The following is a description of a gene set: Hypoxia-dependent self-renewal of myoblasts Mouse Gene Set: WP_HYPOXIADEPENDENT_SELFRENEWAL_OF_MYOBLASTS species: Mus musculus, and this is the list of marker genes: Myod1, Pax7, Hey2, Myog, Hes1, Foxo1, Hif1a, Hey1, Hsp90b1, Myh1, Notch1, Myf5, Cdkn1a